The following is a description of a gene set: Human Gene Set: NABA_COLLAGENS One hallmark of ECM proteins is their domain-based structure. Exploiting this characteristic, we established a list of diagnostic InterPro domains commonly found in ECM proteins. We know that some of the domains used to select positively for ECM proteins are also found in transmembrane receptors and proteins involved in cell adhesion (growth factor receptors, integrins, etc) that do not belong to the ECM. These families of proteins also display a subset of specific domains and transmembrane domains incompatible with definition as “extracellular matrix” proteins. Therefore, a second step comprised a negative selection using another set of domains and a transmembrane domain prediction. Manual curation of the matrisome lists also allowed us to add a very few known ECM proteins that do not contain any known domains. Protein-centric predictions were then converted to gene-centric lists. Finally, knowledge-based annotation of these gene lists allowed us to define subcategories within the core matrisome; namely, ECM glycoproteins, collagens, and proteoglycans. We also defined separate lists of domains commonly found in 1) ECM-affiliated proteins (proteins that share either some architectural similarities with ECM proteins or that are known to be associated with ECM proteins; 2) ECM regulators: ECM-remodeling enzymes, crosslinkers, proteases, regulators etc.; 3) secreted factors, many of which are known to bind to ECM and others that may. As for the core matrisome list, we also defined lists of domains that excluded mis-assigned proteins from these categories. Using similar bioinformatic pipelines as for the core matrisome, we defined three categories of “matrisome-associated” proteins: ECM-affiliated proteins, ECM regulators, and secreted factors. species: Homo sapiens from publication Naba A, Clauser KR, Hoersch S, Liu H, Carr SA, Hynes RO (PMID 22159717) Genes encoding collagen proteins, and this is the list of marker genes: COL24A1, COL6A5, COL27A1, COL3A1, COL6A2, COL21A1, COL17A1, COL5A3, COL8A2, COL22A1, COL4A6, COL13A1, COL4A3, COL5A1, COL5A2, COL11A1, COL16A1, COL7A1, COL2A1, COL4A2, COL1A2, COL4A1, COL9A2, COL1A1, COL11A2, COL9A3, COL14A1, COL23A1, COL19A1, COL6A1, COL12A1, COL8A1, COL20A1, COL6A6, COL4A4, COL26A1, COL10A1, COL4A5, COL18A1, COL15A1, COL6A3, COL28A1, COL25A1, COL9A1